Given this list of marker genes Clec2i, Rara (retinoic acid receptor, alpha, NCBI Gene Id 19401), Hspa9, Pira1, Myc, Inpp5d, Ctr9, Apcs, Dll1, Clec2d, Bmyc, Hoxa7, Gpr137, Iapp, Gpr171, Itpkb, Meis2, Zbtb46, Adipoq (adiponectin, C1Q and collagen domain containing), Thoc5 (THO complex 5), Cdk6, Pf4, Rbm15, Tnfrsf11b, Prdm16, Fbn1, Ccl21b, Inpp4b, Gata2, Prmt1, Tcta, Stat5b, Lyn, Trib1, Runx1, Pik3r1, Ifng, Ubash3b, Ceacam1, Stat5a, Nfkbia, Lilrb4b, Cldn18, Hoxb8, Skic8, Leo1, Fbxw7, Zfpm1, Pias3, Pilrb1, Gabpa, Tjp2, Ccl3, Ldb1, Nme2, Zfp36l1, Cartpt, Paf1, Clec2g, Ifnb1, Gpr137b, Gpr68, Ypel4, Nf1, C1qc, Ctnnb1, Cul4a, Sfrp1, Erfe, Ltf, Zfp36, Lrrc17, Tob2, Fstl3, Tmem178, Mafb, Qki, Hoxa5, Klf13 (NCBI Gene Id 80528), Nme1, Tnfaip6, Hmgb3, Myb (myeloblastosis oncogene), Twist2, Cib1, Gpr55, Ptpn2, Cdc73, Pira12, Csf1r, Meis1, Lmo2, Lilrb4a, Ptk2b, Il4, Hoxa9, here is a description of the gene set: species: Mus musculus Any process that stops, prevents, or reduces the frequency, rate or extent of myeloid cell differentiation. Mouse Gene Set: GOBP_NEGATIVE_REGULATION_OF_MYELOID_CELL_DIFFERENTIATION